The following is a description of a gene set: studied in species Homo sapiens Human Gene Set: GSE37563_WT_VS_CTLA4_KO_CD4_TCELL_D4_POST_IMMUNIZATION_DN CTLA-4 is thought to inhibit effector T cells both intrinsically, by competing with CD28 for B7 ligands, and extrinsically, through the action of regulatory T cells. We studied in vivo responses of normal and CTLA-4-deficient antigen-specific murine effector CD4+ T cells. In order to do these studies in a physiological model of immunity to foreign antigen, we transferred small numbers of congenically marked RAG2-deficient 5C.C7 T cells with either a normal or knockout allele of CTLA-4 into normal syngeneic B10.A recipient mice. The T cells were then activated by immunization with MCC peptide and LPS. To look for transcriptional signatures of negative regulation of T cell responses by CTLA-4, we used microarray analysis to compare transcripts in wild type and CTLA-4 KO 5C.C7 T cells four days after immunization. This is the first instance in which differences are observed in extent of accumulation of wild type and CTLA-4 KO 5C.C7 T cells. from publication Corse E, Allison JP (PMID 22753941) Genes down-regulated in CD4 cells after immunization: wildtype versus CTLA4 knockout., and this is the list of marker genes: HAUS5, NCAPD3, PIEZO1, CHAC2, WBP11, MFSD10, SORD, IL1R2, BNIP3, PRRC2A, CD38, HMBS, CERS2, PRMT5, NFIL3, H2BC14, TFPI, CIAO2B, DZIP3, LXN, MYCBP (NCBI Gene Id 26292), FASTK, EGLN3, DPYSL2, KIF18B, STAU2, DUSP3, CACNA1C, RMDN3, HAMP, ECE1, TRERF1, MCM4, TECR, PTPRS, GDAP2, COBLL1, LRRFIP1, WAS, PACSIN2, LRRC8C, VAC14, BYSL, ACCS, COX8BP, TMEM184C, PTPN9, H2BC4, PAQR3, BMP7, KLRG1, MRPS11, SMARCA4, A3GALT2, NBEAL2, HMGN5, SLC25A10, COMTD1, LRP8, NFKBIB, PRPF31, ENTPD1, SLC29A4, DST, MYO1G, DPAGT1, CCL22, SESN2, IL2RB, MAN2B2, FADD, SLC15A3, POLR1D, CREM, HAVCR2, C1D, DHRS3, CD44, CANT1 (NCBI Gene Id 619513), TMEM65, GAS2L3, FASN, CDK5RAP1, CHSY1, LPCAT3, TREX1, PRKAR2B, CKS2, NEB, UBC, OTUB1, ITGA2, SERTAD4, SYTL3, PTGER4, WIZ, MAF, SLC2A1, ACOT11, TNFSF9, P2RX7, SKP2, VCL, SPIRE2, ECM1, TMEM176A, SHARPIN (NCBI Gene Id 81858), PLK1, ABHD4, HSPA4L, NACC1, TBC1D7, GTSE1, LMF2, CCNF, ELOVL1, HIP1, TRAPPC1, LAMC1, ABRA, SIRT6, ATF6, ATP2B4, CORO2A, AGFG2, MED25, MXD3, SSR1, KMT5A, GOT1, POLD3, F2RL2, PEDS1, CRIP1, TCERG1, PRDM1, TNK2, ESPN, PGAM1, YIPF3, SMTN, POMP, LRR1, BCAP31, WNK1, PRR5, PAXIP1, ACD, TUBG2, CDCA8, SUV39H1, UCK2, TNS4, H6PD, CD24, FADS2, ZC3H4, CCR4, CENPL, MAPK3, BSCL2, ALG13, ELOA, CKAP2L, PLD4, MYO1C, IPPK, PPAN, SCD, SPRED2, TINF2, LRRC8D, TMEM107, NDC1, CRTAP, GPD2, LDHB, CDKN3, CD74, GLRX, SF3B4, SLC25A11, BTD, VIM, NSDHL